Given this list of marker genes OR5T3, GDF1, DOK6, CERS1, TRAF7, GATA4, LCN6, MAGEA1, GPSM1, TOP3A, MAFG, NPB, MPRIP, TMEM51-AS1, KRT38, DIRAS1, ANAPC11, KRT33B, ALYREF, NDUFA4, MAFK, OSBPL11 (oxysterol binding protein like 11), UPF1, TOP1, FLII, CCNYL1, PYCR1, LLGL1, FSTL3, EIF1, KRT37, PTPRD, KRT13, SHMT1, GAST, DUSP1, BOP1, CASKIN1, MSI2, BRSK2, LCN15, ANKRD10, HAP1, PAX9, PEX5L, DACH1, ZDHHC8 (zinc finger DHHC-type palmitoyltransferase 8), CSDE1, MYO15A, RPS15, DAZAP1, SIRT7, DNASE1, CARD9 (NCBI Gene Id 64170), PANK4, OR8H1, KRT32, KRT36, APC2, YY1AP1, NEUROG2, CCDC144BP, CCDC103, PRKN, RASD1, KRT34, C4orf36, MAPKAPK5, LCN8, USP32P2, FBXO3, RXRA, KRT15, GPALPP1, MIEF2, CANT1, NOTCH1, NRAS, NOTUM, LINC02076, XPNPEP1, C1orf220 (chromosome 1 putative open reading frame 220), PCYT2 (phosphate cytidylyltransferase 2, ethanolamine), KRT35, HJV, KRT31, KAZN, OR5T1, KRT33A, SMCR8, P4HB, EFTUD2, LCN10, here is a description of the gene set: Genes from chromosomal copy number gains in a panel of 51 primary colon carcinoma samples. Genomic aberrations on chromosome 8 are common in colon cancer, and are associated with lymph node and distant metastases as well as with disease susceptibility. This prompted us to generate a high-resolution map of genomic imbalances of chromosome 8 in 51 primary colon carcinomas using a custom-designed genomic array consisting of a tiling path of BAC clones. This analysis confirmed the dominant role of this chromosome. Unexpectedly, the position of the breakpoints suggested colocalization with structural variants in the human genome. In order to map these sites with increased resolution and to extend the analysis to the entire genome, we analyzed a subset of these tumors (n = 32) by comparative genomic hybridization on a 185K oligonucleotide array platform. Our comprehensive map of the colon cancer genome confirmed recurrent and specific low-level copy number changes of chromosomes 7, 8, 13, 18, and 20, and unveiled additional, novel sites of genomic imbalances including amplification of a histone gene cluster on chromosome 6p21.1-21.33 and deletions on chromosome 4q34-35. The systematic comparison of segments of copy number change with gene expression profiles showed that genomic imbalances directly affect average expression levels. Strikingly, we observed a significant association of chromosomal breakpoints with structural variants in the human genome: 41% of all copy number changes occurred at sites of such copy number variants (P < 2.2e(-16)). Such an association has not been previously described and reveals a yet underappreciated plasticity of the colon cancer genome; it also points to potential mechanisms for the induction of chromosomal breakage in cancer cells. from publication Camps J, Grade M, Nguyen QT, Hörmann P, Becker S, Hummon AB, Rodriguez V, Chandrasekharappa S, Chen Y, Difilippantonio MJ, Becker H, Ghadimi BM, Ried T (PMID 18316590) species: Homo sapiens Human Gene Set: CAMPS_COLON_CANCER_COPY_NUMBER_UP